The following is a description of a gene set: This event has been computationally inferred from an event that has been demonstrated in another species.<p>The inference is based on the homology mapping from PANTHER. Briefly, reactions for which all involved PhysicalEntities (in input, output and catalyst) have a mapped orthologue/paralogue (for complexes at least 75% of components must have a mapping) are inferred to the other species. part of: Phase II - Conjugation of compounds electronically inferred by orthology from the curated human pathway Reactome Pathway: Methylation species: Mus musculus, and this is the list of marker genes: Mtrr, Nnmt, Mat1a, Trmt112, Mat2a, N6amt1, Tpmt, Cyp1a2